Given this list of marker genes SPG7, FA2H, SELENOI, GALC, ABCD1, TBCE, CPT1C, here is a description of the gene set: studied in species Homo sapiens Progressive spastic paraparesis Human Gene Set: HP_PROGRESSIVE_SPASTIC_PARAPARESIS